Given this list of marker genes DESI2 (desumoylating isopeptidase 2), INSM2, AMMECR1L, MRPL2, OXR1, KIF22, URI1, BTG2, PRKAB1, TAP1, ELAVL4, ACER3, ASF1B, BRD9, PMM1, KLRK1, SGK1 (serum/glucocorticoid regulated kinase 1), RCAN2, ISG20L2, LANCL1, OTULIN, ALDH2, CNOT11, LAMTOR2, USP19, PPT1, TAF5L, H1-2, ARHGAP9, UBAC2, ITGB2, CLEC4A, COMMD2, SP3 (NCBI Gene Id 6670), PLBD1, CORO2A, TMEM86A, LY86, WLS, POLA1, VRK3, TMEM176A, CXCL3, ATP6V1F, DNTTIP1, TRAPPC8, ATP13A3, MEMO1, PLA2G7, CLEC7A, TNFRSF13B, GNAQ, THADA, MTPAP, STX7, PPP4R1, RBM38, SLAMF8, CNIH1, UFL1, HCFC1, ICOS, CCDC12, EHBP1L1, MYCBP, YRDC, UBP1, FTH1, AQP8, SLC22A2, RNF125, CNOT1, EIF2B3, RTRAF, CENPF, GAS2L3, RPL3, SGIP1, DNAJB4, CYBA, CA12, RHBDD1 (NCBI Gene Id 84236), FUT11, RBM28, GUSB, BRF1, CAMK2G, HOXD8, SAMSN1, USE1 (unconventional SNARE in the ER 1), CSNK2B, TAPBPL, CPSF7, TRAF3, NDUFS2, DDX19A, EFHD2, RNF130, NEDD4, ZCCHC8, SMIM8, SRPRA, NEDD1, ECT2, CNGA1, FCGR3A, NUBPL, IAH1, XRCC5, NUDT2, USP22, PSME2, ZFP90, MPHOSPH6, UTP18, TTC38, PNO1, CANX, SPCS1 (NCBI Gene Id 94556), NUSAP1, CXCL9, DYNC1LI2 (NCBI Gene Id 1783), LIG1, ABCC1, TNS3, SASS6, CD81 (NCBI Gene Id 975), TRDMT1, DDX28, GSTCD, SOWAHB, NIBAN1, PEX2, TXNL4A, ERLIN1, TAPT1, OSBPL11, TMF1, NOXRED1, MYO1E, TMEM192, TRAFD1, PTPN18, PIGF, RIGI, ANTKMT, AKT2, HTATIP2, MT1E, TMEM176B, JAK1, CSTB, CD14, NDUFB2, KIAA0319L, NMRAL1, IL1RN, NIPSNAP3A, ATRAID, GUCD1, MSH5, CNST, PBK, CALML5, CPNE1, SLC15A3, UBXN7, APOE, ERP29, SERF2, CASP6, SOCS7, AGO1, KPNA3, MAPK14, GRAMD1C, TIRAP, DFFA, CNTRL, ATP2A2, ACVR1B, MAPK1, MED8, GRSF1, RPL24, E2F2, MGST1, DYNLL1, PLD4 (NCBI Gene Id 414770), CST7, GTF2A1, WDR73, CHIC2 (NCBI Gene Id 26511), OSTC, LAMP1, UBE2A, SPRYD7, SORCS3-AS1, WDR81, TLR1, here is a description of the gene set: Genes down-regulated in mature neuron cell line: control versus interferon alpha (12h). studied in species Homo sapiens from publication Peltier DC, Simms A, Farmer JR, Miller DJ (PMID 20483728) Human neuronal differentiation alters responsiveness to innate immune stimuli and virus infections. We used microarrays to examine the transcriptional responses of the human BE(2)-C neuroblastoma cell line to retinoic acid-induced differentiation and type I IFN stimulation. Human Gene Set: GSE16450_CTRL_VS_IFNA_12H_STIM_MATURE_NEURON_CELL_LINE_DN